The following is a description of a gene set: Mouse Gene Set: GOBP_POSITIVE_REGULATION_OF_TYPE_B_PANCREATIC_CELL_APOPTOTIC_PROCESS Any process that activates or increases the frequency, rate or extent of type B pancreatic cell apoptotic process. species: Mus musculus, and this is the list of marker genes: Capn10, Isl1, Ager, Eif2s1, Spop, Hdac3